The following is a description of a gene set: studied in species Homo sapiens Genes predicted to be targets of miRBase v22 microRNA hsa-miR-6801-3p in miRDB v6.0 with MirTarget v4 prediction scores > 80 (high confidence targets). Human Gene Set: MIR6801_3P from publication Chen Y, Wang X (PMID 31504780), and this is the list of marker genes: SLC6A6, SYBU, ZNF442, PTGFRN, AKT3, TTYH3, SNX8 (NCBI Gene Id 29886), EPC2, ZBTB2, ADGRG6, LOXL3, C2CD4C, SNPH, GPAT4, MICOS10, MDN1, CLPP, SLC9A1, TSLP, CHST11, NRP2, CHD8, SEMA7A, PMEPA1, PTPN2, SLC45A4, PHAF1, GRHL1, NUP210L, FBRS, ZNF268, BLZF1, RIMS3, TBC1D16 (TBC1 domain family member 16), KDM5B, GAB2, CDADC1, ZNF652, PCBP4, RBFA, DNMT3B, SENP3, OTX2, PLSCR3, FBXW11, ZNF37A, FAM78B, MIER3, RABGEF1, DIP2B, DST